Given this list of marker genes PROP1, FN1, IYD, GLB1, TINF2, AIFM1, TSHR, RSPRY1, EIF2AK3, TONSL, DUOX2, B3GALT6, SIL1, COL9A1, SKIC3, PIK3C2A, TRPV4, TSHB, HS2ST1, RET, SLC26A2, IFT140, RTL1 (NCBI Gene Id 651665), ADAMTS2, DNAJC21, NEK9, DLK1, SLC5A5, UNC45A, TBX4, KIF22, RINT1, COL1A1, RNU4ATAC, COL9A2, COL10A1, LHX3, HESX1, EP300 (NCBI Gene Id 2033), GNPTG, HSPG2, UFSP2, CSPP1, SLC2A10, POU1F1, DVL1, BRF1, BMP4, PEX5, COL9A3, CREBBP, WNT5A, SLC39A13, PCNT, CCN6, TG, DVL3, TRPS1 (NCBI Gene Id 7227), CANT1, ATP7A (NCBI Gene Id 613259), CHST3, KIAA0586, ADAMTSL2, TBC1D2B (TBC1 domain family member 2B), DYM, SBDS (SBDS ribosome maturation factor), RPL13, TPO, EXTL3, COL2A1, MATN3, CDC6, EXT1, EFL1, DUOXA2, IHH, PLOD3, MEG3, LHX4, ARSL, SRP54, TRAPPC2, TREX1, COMP, COL11A1, RAB3GAP2 (NCBI Gene Id 26114), COL11A2, SRCAP, ACAN, FZD2, RAD21, COL1A2, COG1, SMARCAL1, here is a description of the gene set: species: Homo sapiens Human Gene Set: HP_ABNORMAL_LOWER_LIMB_EPIPHYSIS_MORPHOLOGY Abnormal lower limb epiphysis morphology An anomaly of one or more epiphyses of one or both legs.